Given this list of marker genes Unc5c, Plscr4, B3gnt9, Gpatch8, Pilra, Zfp120, Nipa2, Prdm4, Kynu, Ercc6l, Dsc2, Agap1, Zfp758, Fnbp4, Epha5, Bbs12, St8sia2, Gng7, Gli2, Cd2bp2, Hs3st3b1, Tmem183a, Spry2, Grk1, Prtg, Ddias (DNA damage-induced apoptosis suppressor), Frmd6, Slc26a8, Itga9 (integrin alpha 9), Ubl3, Pbx1, Apbb2, Astl, Grm6, Pnkd, Scamp1, B4galt1, Csnk2a1, Xcr1, Sumo2 (NCBI Gene Id 235709), Rrm2b, Insyn2a, Cldn23, Pax3, Colgalt2, Dlx3, Fbxw7, Ctdp1, Aak1, Nid1, Tmed8, Utf1, Btbd10 (BTB domain containing 10), Hspb6, Zfp113, Slc16a2, Adarb1, Zfand5, Dync1h1, Samd5, Mtcl2, Alpl, Lipa, Tmem240 (NCBI Gene Id 633976), Set, Tubb5, Pik3r3, Cdc45, Scimp, Klk5, Ttll7, Adgrd1, Pm20d1, 5031439G07Rik, Cops2 (COP9 signalosome subunit 2), Glce (NCBI Gene Id 93683), Acvr2b, Bcl7a, Xpo7, I830077J02Rik, Pcdh9, Tmem127, Magi3, Sipa1l1, Fam219a, Epc1, Olr1, Dnajc11, Rab11fip4, Cxcl16, Tox3, Smarcad1, Ptp4a1, Tspan5, Aldh1a1, Ehbp1, Mcrs1, Fam163a, Tcf12, Macrod2, Sik3 (SIK family kinase 3), Ptchd4, Tlx1, here is a description of the gene set: from publication Chen Y, Wang X (PMID 31504780) species: Mus musculus Mouse Gene Set: MIR_5114 Genes predicted to be targets of miRBase v22 microRNA mmu_miR_5114 in miRDB v6.0 with MirTarget v4 prediction scores > 80 (high confidence targets).